The following is a description of a gene set: Mouse Gene Set: GOBP_POSITIVE_REGULATION_OF_MITOTIC_SISTER_CHROMATID_SEPARATION studied in species Mus musculus Any process that activates or increases the frequency, rate or extent of mitotic sister chromatid separation., and this is the list of marker genes: Ska3, Cdca8, Mad2l1bp, Ska1, Cdc20, Cdc23, Anapc5, Birc5, Prap1, Nsmce2, Cul3, Anapc11, Mad1l1, Cdc16, Cenpe, Anapc7, Ube2c, Rb1, Incenp, Aurkb